Given this list of marker genes Fgf3, Stox1, Dkk1, Frs2, Msx1, Bmp4, Mir875, Robo1, Hoxa11, Hoxd11, Bmp2 (NCBI Gene Id 98992), Gdnf, Fgfr4, Six1, Wnt2b, Mesp1, Fgfr1, Sox9, Csf1, Wnt4, Fgf2, Ar, Fgf10, Ngfr (NCBI Gene Id 18053), Edn1, Gata5, Hoxc11, Tgfb1, Spry1, Robo2, Sox8, Fgf1, Ctnnb1, Fgf8, Ednra, Gata3, Wnt2, Prkcb, Six4, Cd34, Rbpj, here is a description of the gene set: Mouse Gene Set: GOBP_POSITIVE_REGULATION_OF_ANIMAL_ORGAN_MORPHOGENESIS Any process that activates or increases the frequency, rate or extent of animal organ morphogenesis. species: Mus musculus